The following is a description of a gene set: Genes predicted to be targets of miRBase v22 microRNA hsa-miR-3684 in miRDB v6.0 with MirTarget v4 prediction scores > 80 (high confidence targets). from publication Chen Y, Wang X (PMID 31504780) species: Homo sapiens Human Gene Set: MIR3684, and this is the list of marker genes: PCDH9, FUT4, SRSF8, C11orf58, ALAD, TSC1, ITGAX, ZNRF3, ZBTB18, YWHAG, DSP, TIAM1, GGCX, SHC1, DYNAP, STC1, TRIM23, BHLHE22, MGARP, DLEU7, VLDLR, ZIC4, UBE2D2, GCH1, PRDM10, TCP10L, MBNL2, EXOC1, CCT2, TRMT1L